The following is a description of a gene set: A protein complex formed by the association of several methylated Sm proteins with the SMN complex; the latter contains the survival motor neuron (SMN) protein and at least eight additional integral components, including the Gemin2-8 and unrip proteins; additional proteins, including galectin-1 and galectin-3, are also found in the SMN-SM complex. The SMN-Sm complex is involved in spliceosomal snRNP assembly in the cytoplasm. species: Homo sapiens Human Gene Set: GOCC_SMN_SM_PROTEIN_COMPLEX, and this is the list of marker genes: DDX20, GEMIN4, GEMIN7, GEMIN8, SNRPB, SMN1, SNRPGP15, SNRPD1, SMN2 (survival of motor neuron 2, centromeric), FMR1, SNRPF, GEMIN2, SNRPE, SNRPD2, SNRPG, GEMIN5, STRAP, GEMIN6, SNRPD3